The following is a description of a gene set: Retroviral tagging previously identified putative cancer-causing genes in a mouse brain tumor model where a recombinant Moloney murine leukemia virus encoding the platelet-derived growth factor B-chain (MMLV/PDGFB) was intracerebrally injected in newborn mice. In the present study, expression analysis using cDNA arrays revealed several similarities of virus-induced mouse gliomas with human brain tumors. Brain tumors with short latency contained on average 8.0 retroviral insertions and resembled human glioblastoma multiforme (GBM) whereas long-latency gliomas were of lower grade, similar to human oligodendroglioma (OD) and had 2.3 insertions per tumor. Several known and novel genes of tumor progression or cell markers were differentially expressed between OD- and GBM-like tumors. Array and quantitative real-time PCR analysis demonstrated elevated expression similar to Pdgfralpha of retrovirally tagged genes Abhd2, Ddr1, Fos, Ng2, Ppfibp1, Rad51b and Sulf2 in both glioma types compared to neonatal and adult normal brain. The retrovirally tagged genes Plekhb1, Prex1, Prkg2, Sox10 and 1200004M23Rik were upregulated in the tumors but had a different expression profile than Pdgfralpha whereas Rap1gap, Gli1, Neurl and Camk2b were downregulated in the tumors. The present study accentuates the proposed role of the retrovirally tagged genes in PDGF-driven gliomagenesis and indicates that insertional mutagenesis can promote glioma progression. Mouse Gene Set: JOHANSSON_GLIOMAGENESIS_BY_PDGFB_DN from publication Johansson FK, Göransson H, Westermark B (PMID 15750623) studied in species Mus musculus Genes down-regulated in brain tumors induced by retroviral delivery of PDGFB., and this is the list of marker genes: Ctnnd1 (NCBI Gene Id 99192), Acot7, Wipf3, Nefl, Slc30a3, Caly, Arpp19, Ppp3ca, Kcnh3, Prkcz, Hba-a1, Syngr3, Ppp1r1b, Tyro3 (NCBI Gene Id 98916), Rph3a, Fam131a (family with sequence similarity 131, member A), Fgfr2, Chmp3, Kifc2, Mat2b, Cacnb3, Chn1